The following is a description of a gene set: Reactome Pathway: Protein ubiquitination electronically inferred by orthology from the curated human pathway species: Mus musculus part of: Post-translational protein modification This event has been computationally inferred from an event that has been demonstrated in another species.<p>The inference is based on the homology mapping from PANTHER. Briefly, reactions for which all involved PhysicalEntities (in input, output and catalyst) have a mapped orthologue/paralogue (for complexes at least 75% of components must have a mapping) are inferred to the other species., and this is the list of marker genes: Prkdc, Pcna, H2bc12, H2bc22, Ctr9, H2bc1, Ube2g1, Ube2w, Rnf40, Cdc34, Ube2k, Usp5, Rnf152, Leo1, H2bc3, H2bc15, Pex13, Ube2e3, Uba1, Uchl3, Pex12, Rps27a, Rraga, Ube2n, Pex5, Ube2r2, Ube2e1, H2bc11, H2bc8, H2bc7, H2bc13, H2bc9, Ubb, Ube2c, Ube2d1, Ube2s